The following is a description of a gene set: Human Gene Set: GOCC_PHOTORECEPTOR_CONNECTING_CILIUM species: Homo sapiens The portion of the photoreceptor cell cilium linking the photoreceptor inner and outer segments. It's considered to be equivalent to the ciliary transition zone., and this is the list of marker genes: IQCB1, IFT140, KIFAP3, TMEM237, IFT57, SPATA7, SPTBN5, LCA5, TSGA10IP, IFT20, PCDHB13, WHRN, TTC8, GNAT1, NPHP1, POC5, USH1G, RP1L1, WDR19, TBCC, CEP290, ARL3, KIF17, IFT122, RPGRIP1, RPGR, MYO7A, RAB37, CETN1, RPGRIP1L, FAM161A, KIAA1549, PCDHB15, NPHP4, CFAP410, BBS4, USH2A, TOPORS, RP1, CETN2, SEPTIN2, MAK, IFT52, CETN3